The following is a description of a gene set: Mouse Gene Set: LEIN_NEURON_MARKERS Molecular approaches to understanding the functional circuitry of the nervous system promise new insights into the relationship between genes, brain and behaviour. The cellular diversity of the brain necessitates a cellular resolution approach towards understanding the functional genomics of the nervous system. We describe here an anatomically comprehensive digital atlas containing the expression patterns of approximately genes in the adult mouse brain. Data were generated using automated high-throughput procedures for in situ hybridization and data acquisition, and are publicly accessible online. Newly developed image-based informatics tools allow global genome-scale structural analysis and cross-correlation, as well as identification of regionally enriched genes. Unbiased fine-resolution analysis has identified highly specific cellular markers as well as extensive evidence of cellular heterogeneity not evident in classical neuroanatomical atlases. This highly standardized atlas provides an open, primary data resource for a wide variety of further studies concerning brain organization and function. from publication Lein ES, Hawrylycz MJ, Ao N, Ayres M, Bensinger A, Bernard A, Boe AF, Boguski MS, Brockway KS, Byrnes EJ, Chen L, Chen L, Chen TM, Chin MC, Chong J, Crook BE, Czaplinska A, Dang CN, Datta S, Dee NR, Desaki AL, Desta T, Diep E, Dolbeare TA, Donelan MJ, Dong HW, Dougherty JG, Duncan BJ, Ebbert AJ, Eichele G, Estin LK, Faber C, Facer BA, Fields R, Fischer SR, Fliss TP, Frensley C, Gates SN, Glattfelder KJ, Halverson KR, Hart MR, Hohmann JG, Howell MP, Jeung DP, Johnson RA, Karr PT, Kawal R, Kidney JM, Knapik RH, Kuan CL, Lake JH, Laramee AR, Larsen KD, Lau C, Lemon TA, Liang AJ, Liu Y, Luong LT, Michaels J, Morgan JJ, Morgan RJ, Mortrud MT, Mosqueda NF, Ng LL, Ng R, Orta GJ, Overly CC, Pak TH, Parry SE, Pathak SD, Pearson OC, Puchalski RB, Riley ZL, Rockett HR, Rowland SA, Royall JJ, Ruiz MJ, Sarno NR, Schaffnit K, Shapovalova NV, Sivisay T, Slaughterbeck CR, Smith SC, Smith KA, Smith BI, Sodt AJ, Stewart NN, Stumpf KR, Sunkin SM, Sutram M, Tam A, Teemer CD, Thaller C, Thompson CL, Varnam LR, Visel A, Whitlock RM, Wohnoutka PE, Wolkey CK, Wong VY, Wood M, Yaylaoglu MB, Young RC, Youngstrom BL, Yuan XF, Zhang B, Zwingman TA, Jones AR (PMID 17151600) Genes enriched in neurons in the adult mouse brain identified through correlation-based searches seeded with neuron cell-type specific gene expression patterns. species: Mus musculus, and this is the list of marker genes: Faim2, Camk2a, Smarca2, Pacsin1, Ptprn, Disp2, Cyfip2, Cyria, Gabbr2 (gamma-aminobutyric acid type B receptor subunit 2), Gap43, Norad, Flywch1, Chgb, Gria2, Chn1, Gria3, Nsg2, Snhg11, Tuba4a, Rab6a, Sh3gl2, Lrp11, Gria4, Clstn3, Ywhag, Map2k4, Alcam, Add2, Jakmip1, Myo5a, Atp6v1g2, Prkar1b, Snrpn, Ndrg4, Egr1, Cplx1, Kifc2, Phf24, Unc80, Syt1, Fbxw5, Bmerb1, Lhx9, Uchl1, Trank1, Gpr162 (G protein-coupled receptor 162), Madd, Cx3cl1, Grin2b, Snap25, Napb, Chst1, Map2k1, Reps2, Gabarapl1, Syp, Dpp6, Prkaca, Ryr2, Camk2b, Meg3, Slc22a17, Tcaf1, Bex2, Ndfip1, Nefl (NCBI Gene Id 18039), Calm2, Rtn1, Syngr3